The following is a description of a gene set: species: Homo sapiens Genes in the cancer module 208. Human Gene Set: MODULE_208, and this is the list of marker genes: HLA-DMA, CEBPD, CD79A, OAS1, CD8B, IFI44L, PELI1, CCDC186, AQP9, SAMSN1, KLF6, GNLY, CPVL, IL3RA, ABTB1, APOL3, LIMD2, CD5, UNC5D, HLA-DMB, BANK1, HLA-DQA1, HLA-DQB1, FAM53B, CD2, IL2RB, CCL18, SELP, LILRB1, IL7R, THBS1, TXNIP, FOXP1, OAS3, IFI35, CD3D, HELZ2, PPP1R16B, KCNA3, CSF3, PTTG1, KCTD12, KCNQ5, TNFSF10, HLA-DRA, CD48, TTLL2, TNFRSF25, ZNF292, UTY, CFB, XCL1, KLRK1, GBP1 (NCBI Gene Id 2633), GZMA, VCAM1, HVCN1, STAG3, LGMN, ADAM19, IFI44, PLSCR1, CTSL, MX2, GBP2, IGHG3, CACNG4, IFT70A, POLR3B, CARD16, CD14, CD74, TNFAIP6, CCL7, TPTE2, FPR1, FADS1 (fatty acid desaturase 1), IGLJ3 (immunoglobulin lambda joining 3), MS4A1, MAL, CXCL13, TCF7, HLA-DPA1, RNF31, S1PR1, AXIN1, NLRC5, HLA-DRB3, CD200 (NCBI Gene Id 4345), CMAHP, TXLNGY, IFITM2, NEK11, IFITM1, IFITM3, KIAA0753, SDC2 (NCBI Gene Id 6383), SERPINA5, MCU, ISG15, RRP15, DEFA1, SLC40A1, PNMA8A, LPAR6, IGKC, GMCL1, P2RY10, CNRIP1, CYP1B1, IFIT5, HBA2, CMKLR1, STK31, CXCL9, CD86, IFIT1, CAMK4, IGHM, TREM1, IL15, HLA-DPB1, USP30, UNC79